The following is a description of a gene set: species: Mus musculus A process carried out by gene products in an organism that enable the organism to engage in a symbiotic relationship, a more or less intimate association, with another organism. The various forms of symbiosis include parasitism, in which the association is disadvantageous or destructive to one of the organisms; mutualism, in which the association is advantageous, or often necessary to one or both and not harmful to either; and commensalism, in which one member of the association benefits while the other is not affected. However, mutualism, parasitism, and commensalism are often not discrete categories of interactions and should rather be perceived as a continuum of interaction ranging from parasitism to mutualism. In fact, the direction of a symbiotic interaction can change during the lifetime of the symbionts due to developmental changes as well as changes in the biotic/abiotic environment in which the interaction occurs. Microscopic symbionts are often referred to as endosymbionts. Mouse Gene Set: GOBP_BIOLOGICAL_PROCESS_INVOLVED_IN_SYMBIOTIC_INTERACTION, and this is the list of marker genes: Chmp6, Cd300ld, Dao, Ist1, Grk2, Arg1, Pglyrp4, Scnn1b, F2, Dynlt1c, Dynlt1b (NCBI Gene Id 21648), Trem1, Vps4b, Romo1, Hs3st5, Smpd1, Pglyrp1, Chmp4b, Mbl1, Siva1, Vamp8, Cldn1, Cxcl1, Pomc (pro-opiomelanocortin-alpha), Cldn9, Agtr1b, Myd88, Tmprss11d, Cd4, Cd81, Ace2, Bsg, AU040320, Gapdhrt, Dag1, Arl8b, Akt1 (NCBI Gene Id 268604), Rnasek, Vapb, Slamf1, Xpr1, Gbp6, Trim11, Trim30a, Nlrp6, Nectin4, Fn1, Trim25, Trim5, Cd209e, Hrg, Hspd1, Phb1, Ctsb, Bcl2l11, Vps16, Gbp7, Pglyrp2, Dynlt1f, Mbl2, P4hb, Tmprss11a, Spag11b, Jpt2, Rab7, Cd74, Agtr1a, Myh9, Naip5, Vps37b, Gbp2b, Icam1, Gbp3, Gapdhrt2, Scarb1, Gpx1, Cd300lf, Bst2, Trim30b, Vapa, Plg, Camp, Nrp1, Npc1, Gpr15, Chmp2a, Ddb1, Trim31, Hyal2, Kpna6, Pglyrp3, Cysrt1, Nectin2, Eps15, Tmprss2, Ctsg, Chmp5, Lgals1, Insr, Axl, Itgav, Tmprss11e, Gbp9, Tsg101, Ch25h (cholesterol 25-hydroxylase), Bad, Ltf, Gbp2, Chmp2b, Slc7a1, Avpr1b, Vps4a, Fbln1, Clec4g, Vps18, Hsp90ab1, Pcx, Cd209d, Chmp7, Cav2, Tmprss4, Kpna2, Trim30d, Exoc2, Itgb3, Trim30c, Exoc7, Ncf1, Slc20a2, Ceacam1, Pikfyve, Chmp1a, Nectin1, Cav1, Nectin3, Elane, Cxcl5, Gapdh, Hmgb1, Dynlt1a, Tpcn2, Ilf3, Fuca2, F2rl1, Tyro3, Clec5a, Chmp1b2, Chmp4c, Becn1, Furin, Pcyox1l, Cldn6, Trim38, Avp, Bpifa5, Apol11a, Gpx2, Ppara, Uvrag, Gapdh-ps15, Slc3a2, Cd209c, Dpp4, Bpifa1, Chmp1b, Tpcn1, Siglec1, Spint1, Trim12c, Lrrc15, Zfp639, Trim12a, Defa20 (NCBI Gene Id 68009), Tusc2, Tnfrsf14, Trim15, Chmp3, Trim62, Trem3, Fmr1, Gas6